The following is a description of a gene set: studied in species Mus musculus Selected genes down-regulated during invasion of lymphatic vessels during metastasis. Invasion of lymphatic vessels is a key step in the metastasis of primary tumors to draining lymph nodes. Although the process is enhanced by tumor lymphangiogenesis, it is unclear whether this is a consequence of increased lymphatic vessel number, altered lymphatic vessel properties, or both. Here we have addressed the question by comparing the RNA profiles of primary lymphatic endothelial cells (LEC) isolated from the vasculature of normal tissue and from highly metastatic T-241/vascular endothelial growth factor (VEGF)-C fibrosarcomas implanted in C57BL/6 mice. Our findings reveal significant differences in expression of some genes (i.e., >or=2-fold up- or down-regulated, P <or= 0.05) that code for a variety of proteins including components of endothelial junctions, subendothelial matrix, and vessel growth/patterning. The tumor LEC profile, validated by immunohistochemical staining, is distinct from that of normal, inflammatory cytokine, or mitogen-activated LEC, characterized by elevated expression of such functionally significant molecules as the tight junction regulatory protein endothelial specific adhesion molecule (ESAM), the transforming growth factor-beta coreceptor Endoglin (CD105), the angiogenesis-associated leptin receptor, and the immunoinhibitory receptor CD200, and reduced expression of subendothelial matrix proteins including collagens, fibrillin, and biglycan. Moreover, we show similar induction of ESAM, Endoglin, and leptin receptor within tumor lymphatics in a series of human head and neck and colorectal carcinomas, and uncover a dramatic correlation between ESAM expression and nodal metastasis that identifies this marker as a possible prognostic indicator. These findings reveal a remarkable degree of phenotypic plasticity in cancer lymphatics and provide new insight into the processes of lymphatic invasion and lymph node metastasis. from publication Clasper S, Royston D, Baban D, Cao Y, Ewers S, Butz S, Vestweber D, Jackson DG (PMID 18794116) Mouse Gene Set: CLASPER_LYMPHATIC_VESSELS_DURING_METASTASIS_DN, and this is the list of marker genes: Gpc1, Nt5e, Rdx, Loxl1, Jam2, Col6a2, S1pr3, Col5a1, Timp1, Col6a1, Twist2, Sdc2, Emilin2, Col5a2, Ltbp2, Cxcl5, Lox (NCBI Gene Id 16948), Sdc1, Pcolce2, Lpar1, Col3a1, Col6a3, Ltbp1, Bgn, Vcan, Lama2, Foxc2, Cdh11, Pcolce, Fbn1, Robo1, Cdh2, Sema3c, Syk, Col1a2